Given this list of marker genes MSH4, BTG4 (BTG anti-proliferation factor 4), NR5A1, AR, SMARCE1, BMP15, POR, CTNNB1, CYP17A1, SMO, MAP3K1, PIK3CA, XRCC2, SPIDR, GNRH1, NF2, FEZF1, PDGFB, TP53, MRPS22, GATA4, PRKAR1A, STAG3, FSHR, DHH, AKT1, LEP, BNC1, VAMP7, FOXL2, PSMC3IP, LEPR, SYCP2L, SOX9, HROB, NR0B1, SEMA3A, FSHB, DHX37, ESR1, ZSWIM7, POLR3A, ESR2, POLR3H, BAP1, CYB5A, SUFU (SUFU negative regulator of hedgehog signaling), SMARCB1, MCM9, WT1, NDNF, TERT, LARS2, CTDP1, GDF9, SOHLH1, TP63, WWOX, KISS1, SRY, ZNRF3, NUP107, ZFPM2, CDKN2A, TRAF7, here is a description of the gene set: Abnormal circulating estrogen level studied in species Homo sapiens A deviation from normal concentration of the hormone estrogen in the blood circulation. Human Gene Set: HP_ABNORMAL_CIRCULATING_ESTROGEN_LEVEL